The following is a description of a gene set: This event has been computationally inferred from an event that has been demonstrated in another species.<p>The inference is based on the homology mapping from PANTHER. Briefly, reactions for which all involved PhysicalEntities (in input, output and catalyst) have a mapped orthologue/paralogue (for complexes at least 75% of components must have a mapping) are inferred to the other species. electronically inferred by orthology from the curated human pathway part of: FXIIa activates plasma kallikrein-kinin system Reactome Pathway: Regulation of FXIIa and plasma kallikrein activity studied in species Mus musculus, and this is the list of marker genes: Plaur, A2m, F12, Hrg, Kng2, Klkb1, Serping1